Given this list of marker genes REPIN1, ELP1, LARS1, C2CD3, CCDC82, NAB1, FANCL, USP37, ZNF655, EPC2, NAA25, LUC7L3, SS18L1, ANKRD17, KHDC4, NAA30, DMTF1, ZFP14, NCOA5, ZNF512, PATZ1, CHTOP, ZMYM2, CRNKL1, here is a description of the gene set: Neighborhood of FANCL Neighborhood of FANCL Fanconi anemia, complementation group L in the GCM expression compendium Human Gene Set: GCM_FANCL species: Homo sapiens